Given this list of marker genes Or51d1, Camkmt, Nmt1, Or10h5, Tas2r120, Lrp2, Or8b56, Rdh5, Itpr3, Sdc1, Apoa4, Or56a4, Or6f1, Or2w3, Akr1c6, Tas2r130, Or8u9, Dhrs3, Apom, Akr1b10 (aldo-keto reductase family 1, member B10), Or2t48, Or10j5, Or9g20, Gnal, Rbp1, Apoe (apolipoprotein E), Opn1mw, Or5k1, Or11h4b, Hsd17b6, Or8b3b, Or8d23, Or2a57, Plb1, Myo7a, Or10s1, Calm3, Abca4, Or4f4-ps1, Fntb, Or2t43, Or4c12, Guca1a, Rho, Fnta, Or1e1c, Or1d2, Or10g7, Gucy2e, Tas1r3, Or11a4, Guca1b, Tas1r2, Calm1, Or1n2, Sdc4, Or13c3, Gpc3, Or4q3, Tas2r137, Lrp12, Gpc4, Gng13, Or5k1b, Rdh12, Or2a51, Or11h6, Or4f17-ps1, Or10h1b, Akr1c20, Gnb5, Clps, Sag, Gnb3, Nmt2, Or4l1, Or2b11, Sdr9c7, Or2w1, Cnga1 (NCBI Gene Id 12788), Metap1, Tas2r106, Or2t1, Apoc2l, Or5d14, Rcvrn (recoverin), Or2f1b, Grk4, Lrp10, Gpc1, Rpe65, Or2c1, Agrn, Bco2, Apoa2, Or51e1, Pde6g, Or8b3, Metap2, Tas2r118, Akr1c21, Tas2r138, Gnb1, Gpc6, Gnat3, Awat2, Tas2r139, Or10g9b, Tas2r140, Or8k3, Tas2r108, Or6p1, Or4d2b (NCBI Gene Id 258406), Gucy2f, Sdc2, Rdh10, Lrat, Stra6, Cngb1, Gngt1, Rbp3, Or51ai2, Or2at4, Scnn1g, Calm2, Pnlip, Lpl, Apoa1, Or10g9, Or7g27, Or1a1b, Lrp8, Or14j1, Scnn1b, Cyp4v3, Or5p80, Scnn1a, Tas2r119, Or5al1, Or10g3, Ttr, Opn1sw, Lrp1, Bco1, Rdh11, Or10x1, Tas2r121, Or2t29, Or2f1, Or2t46, Or2j3, Or10a49, Or14a260, Or4f4b, Or7d9, Dhrs9, Or2l13, Rbp2, Or2t47, Pde6b, Rlbp1, Tas2r126, Tas1r1, Tas2r144, Rgs9bp, Grk1, Sdc3, Or1e1, Or10h1, Gnat1, Rgs9, Gpihbp1, Gpc2, Apoc2, Tas2r136, Apob, Or2t49, Ppef1 (protein phosphatase with EF hand calcium-binding domain 1), Rdh1, Rbp4, Gpc5, Or51e2, Or2a20, here is a description of the gene set: species: Mus musculus Sensory Perception Mouse Gene Set: REACTOME_SENSORY_PERCEPTION